Given this list of marker genes Rbm12, Tmem196 (NCBI Gene Id 217951), Exosc9, Igf2bp3, Adam22, Gigyf2, Htr1f (NCBI Gene Id 15557), Pcm1, Isg20, Itm2c, Slc5a3, Zrsr2, Myo10, Tmed8, Slc39a6, Pou3f2, Bet1, Tmem106a, Tanc2, Psmc6, Iqch, Fsd1l, Ddx6, Gtf2h1, Inpp4b, Sptssb, Nsd1, Esp5, Jph1, M6pr, Etv5, Cd28, Myef2, Tcea1, Tex2, Psd3, Abca5, Prkg1, Tcerg1, Mpeg1, Spred1, Lrp8, Dclk1, Gabra2, Ube2j1, Defb30, Ankrd40, Bbof1, Eif3j1, Trpv1, Jade1, Diras2, Ubn2, Csmd1, Fam83d, Ammecr1, Abhd2, Tmem231, Pdgfd, Ankrd7, Syt5, Saxo2, Ikzf2, Ttc33, Frk, Slc25a36, Eif3j2 (eukaryotic translation initiation factor 3, subunit J2), Creb1, Insl5, Rapgef6, Cdh3, Armcx6, Fgfr1, Cbx2, Rbbp5, Trps1, Plaur, Hapln1, Otud6b, Atoh1, Nfkb1, Bach1, Ptprm, Mef2a, Eloa, Gtf3c3, Pan3, Dnal1, Rab8b, Sele, Tardbp, Rock2, Slc4a10, Six6, Txndc17, Dlx1, Fntb, Fam168a, Dnajc16, Zfp423, Car8, Wdfy3, Crispld1, Zfp597, Rap2a, Nsmce3, Col6a3, Trip12, Elavl4, Kif3c, Zbtb34, Trim2, Tle1, Glrx, Faf2, Hmgb1, Scp2, Miga1, Gphn, Septin12, Iws1, Gpr173, Ltn1, Gfpt2, Trim58, Zfp462 (NCBI Gene Id 242466), Mtdh, Dock5, Pja1 (praja ring finger ubiquitin ligase 1), Gna13, Csnk1a1, Slc27a6 (NCBI Gene Id 225579), Cmpk1, Srpra, Dpysl5, Gcn1, Sub1, 1700025G04Rik, Slc24a2, Epc1, Sin3a, Ndnf, Slitrk2, Foxj2, Gnptab, Maml1, Cd86, Trappc8, Cflar, Abhd17c, Zdhhc21, Tgm4, Ncor1 (NCBI Gene Id 320690), Il22ra2 (interleukin 22 receptor, alpha 2), Tcf4, Meox2, Hif1a, Lmod1, Cox14, Kctd8, Pcdh10, Hipk1, Ereg, Bmi1, Zfp950, Ncoa2, Unc80, F12, Bmpr2, Zfp148, Mosmo, Tjp1, Grm5, Saal1, Dpp8, Nkrf, Taf1b, Pakap, Macrod2, Mat2a, Olig1, Adat1, Synpo2l (synaptopodin 2-like), Ptk2b, Bmt2, Gnal, Sestd1, Hecw2, Plin5, Ccnd3, Rnf126, Kif1b, Ppp1r9a, Bcap29, Rspo2, Klk11, Trpc5, Lifr, D430041D05Rik, Erbb4, Sf3b3, Gipc1, Irx2, Tmem215, Ube2v1, Yae1d1, Kitl, Timd6, Gls, Nipal1, Adam12, Cert1, Sybu, Tcf12, Rflnb, Spc24, Armc2, Vxn, Nfia, Mybpc1, Pphln1, Itch, Mllt10, Bbx, Tpd52l2, Gria3, Tdrd12, Ebf2, Nlrp10, Kcnb2, Zfp410, Sumf1, Fbxw4, Krt42, Myo5b, Slain1, Yif1a, Uchl5, Rai2, Srsf1, Cyp2a22, Utp15, Cilk1, Tbl1xr1, Sall1, Atp2b1, Ubl3, Zmat3, Sostdc1 (sclerostin domain containing 1), here is a description of the gene set: species: Mus musculus Genes predicted to be targets of miRBase v22 microRNA mmu_miR_330_3p in miRDB v6.0 with MirTarget v4 prediction scores > 80 (high confidence targets). from publication Chen Y, Wang X (PMID 31504780) Mouse Gene Set: MIR_330_3P